Given this list of marker genes ASS1, CPS1, OTC, ARG1, NMRAL1 (NCBI Gene Id 57407), NAGS, SLC25A15, ASL, here is a description of the gene set: studied in species Homo sapiens part of: Diseases of metabolism The urea cycle, also known as the ornithine cycle, is a critical metabolic pathway in the liver that converts toxic ammonia into urea for excretion via the kidneys. This cycle involves a series of enzymatic reactions: Carbamoyl Phosphate Synthetase 1 (CPS1) catalyzes the synthesis of carbamoyl phosphate from ammonia and bicarbonate, requiring activation by N-acetylglutamate (NAG) which is synthesized by N-acetylglutamate synthetase (NAGS). Ornithine Transcarbamylase (OTC) transfers the carbamoyl group to ornithine, forming citrulline. Argininosuccinate Synthetase (ASS1) condenses citrulline with aspartate to form argininosuccinate. Argininosuccinate Lyase (ASL) cleaves argininosuccinate into arginine and fumarate. Arginase (ARG1) hydrolyzes arginine to produce urea and regenerate ornithine. <br>Defects in any of these enzymes or associated transporters can lead to urea cycle disorders (UCDs), resulting in hyperammonemia and neurological impairment. <br>CPS1 deficiency is the most severe UCD, presenting in neonates with lethargy, poor feeding, and seizures due to impaired ammonia detoxification. The clinical presentation of NAGS deficiency is virtually the same as CPS1 deficiency, reflecting the dependence of CPS1 activity on its allosteric activator NAG. <br>The most common UCD is OTC deficiency, an X-linked disorder leading to hyperammonemia and neurological symptoms; males are typically more severely affected. <br>ASS1 deficiency, also known as Citrullinemia Type I is characterized by elevated citrulline and ammonia levels, presenting with lethargy, vomiting, and seizures in infancy. ASL deficiency, also known as Argininosuccinic Aciduria, presents with elevated argininosuccinate and ammonia levels, leading to neurological symptoms and potential liver involvement. ARG1 deficiency causes elevated arginine levels, leading to progressive spasticity and developmental delay. SLC25A15 deficiency, also known as hyperornithinemia-hyperammonemia-homocitrullinuria or HHH Syndrome), arises due to mutations in the transporter that mediates the exchange of cytosolic ornithine for citrulline from the mitochondrial matrix and is also associated with hyperammonemia and neurological symptoms. Reactome Pathway: Diseases of the urea cycle